The following is a description of a gene set: from publication Chen Y, Wang X (PMID 31504780) studied in species Mus musculus Genes predicted to be targets of miRBase v22 microRNA mmu_miR_6352 in miRDB v6.0 with MirTarget v4 prediction scores > 80 (high confidence targets). Mouse Gene Set: MIR_6352, and this is the list of marker genes: Lyst, Saxo1, Rbbp7, Prkn, Pcdhb9 (protocadherin beta 9), Gpr101, Fut10 (fucosyltransferase 10), Nsd1, Mbnl3, Atp6v1g3, Arhgap44, Clvs1, Tenm4, Lhx9, Sim1, Dbpht2, Gpbp1l1, Uevld, Mansc1, Mtcl2, Sephs2, Sars1, Bcap29, Gprasp2, Ptprk, Shisal2b, Carhsp1, Zeb2, Phf8l, Bcas1, Cybrd1, Frmpd4, Evi2a, Mobp, Zfp9, Tesk2, Nhsl1, Cd247, Gne, Hdx, Ctdsp2, Ostn, Spata2, Slc30a7, Zeb1, Nipal1, Utp4, Fhl3, Gls, Irf1, Stk3, Rab14, Relch, Adgra3, Fezf2, Zfp874a, Trps1, Pias3, Uqcc4, Btrc, Fam241a, Cngb3, Pou2f1 (NCBI Gene Id 18986), Jade3, Reep5, Tafa1, Bmp2, 1110059G10Rik, Psat1, Zfp874b, Dpysl3, Heca, Tnfaip3, Hip1, 2510009E07Rik, Krtap2-20, Rnpep, Trim39, Crisp4, Hspa13, Best1, Ccnh, Sf3b3, Scp2, Cbll1 (Casitas B-lineage lymphoma-like 1), Lzts3, Ttpal, Zmynd11, Mboat7, Lrrc19, 5730507C01Rik, Ppip5k1, Dgkb, Prx, Atg4c, Prdm2, Krtap4-16, Sfrp1, Grk4, Pappa, Bnc1, Gm5141 (predicted gene 5141), Cadm1, Clip3, Pcdhb15, Gopc, Phf20, Cdh2, Rfx3, Olfml1, Bmp3, Plekhh1, Lactb, Slc25a21, Ctdspl2, Nrxn1, Lss, Rad1, Chd9, Sgpp1, Pak5, Psip1, Ablim1, Mef2c, Six5, Gulp1, Ints12, Tox (thymocyte selection-associated high mobility group box), Aak1, Esp1, Cep120, Megf10, Dyrk1a, Wdr72, Wbp1l, Crispld1, Armcx4, Cldn34d, Lce3a, Smg9, Mkrn1, Thumpd2, Ddx6, Rrbp1, Msr1, Sprr2f, Abcf3, Mtf2, Eny2, Cyp4a14, Tctn3, Paqr4, Tmed7, Sostdc1, Slc1a3, Prdm8 (PR domain containing 8), Sgcz, Cbx2, Gpc6, Tcf19, Srsf5, Nol3